Given this list of marker genes Zfp385a, Dyrk1a, Muc1, Mif, Nop53, Hapstr1, Mdm4, Rffl, Atad5, Kdm1a, Armc10, Sirt1, Pttg1ip, Pcbp4, Mdm2, Rrn3, Prkn, Sh3glb1, Snai2, Aars1, Psmd10, Cd44, Bdkrb2, Yju2, Ell3, Cep63, Morn3, Bcl2l12, Snai1, Dyrk3, Triap1, Twist1, Rnf34, Marchf7, Cd74, Rrm2b, here is a description of the gene set: species: Mus musculus Mouse Gene Set: GOBP_NEGATIVE_REGULATION_OF_SIGNAL_TRANSDUCTION_BY_P53_CLASS_MEDIATOR Any process that stops, prevents or reduces the frequency, rate or extent of signal transduction by p53 class mediator.